The following is a description of a gene set: studied in species Mus musculus Cell-cell signaling to or from a synapse, mediated by a peptide. Mouse Gene Set: GOBP_SYNAPTIC_SIGNALING_VIA_NEUROPEPTIDE, and this is the list of marker genes: Penk, Npy5r, Grm1, Npy1r, Prkcg (protein kinase C, gamma), Nppa, Grid1, Vgf (NCBI Gene Id 381677), Npy, Cck, Grid2, Syt4